The following is a description of a gene set: Spindle and kinetochore. Human Gene Set: MODULE_315 species: Homo sapiens, and this is the list of marker genes: NEDD9, BUB3, BIRC5, MAD2L1, TBCE, TTK, CDC20, CENPE, CCNA2, BUB1, TUBB3, CENPF, TUBA4A, KIF11, ZW10 (zw10 kinetochore protein), KIF23